The following is a description of a gene set: from publication Chen Y, Wang X (PMID 31504780) Human Gene Set: MIR1178_5P studied in species Homo sapiens Genes predicted to be targets of miRBase v22 microRNA hsa-miR-1178-5p in miRDB v6.0 with MirTarget v4 prediction scores > 80 (high confidence targets)., and this is the list of marker genes: DUSP7, MLEC, FAR1, WARS1, FGF9 (fibroblast growth factor 9), SEPTIN7, ARL10, ELP4, PLXNA4, ASCC2, CARD6, IGF2R, MEX3A, ERC1, RACGAP1, NTRK2, ZDHHC7, ERCC4, TFAP2B, GPATCH2L, OR2H1, RASSF8, ENO4, B4GALT1 (beta-1,4-galactosyltransferase 1), C2orf49, SUDS3, ATP2B1, ANKRD13C, TNFSF10, GTF3C3, MAP2K6, TARS3, GFI1, UTS2B, EIF2S1